The following is a description of a gene set: Subcutaneous lipoma studied in species Homo sapiens Human Gene Set: HP_SUBCUTANEOUS_LIPOMA The presence of subcutaneous lipoma., and this is the list of marker genes: BMPR1A, PTEN, FGFR1, PIK3CA, AKT1, MEN1, CDKN1B